Given this list of marker genes Ep400, Actr6, Ino80e, Trrap, Znhit1, Actr8, Ruvbl2, Ing3, Mcrs1, Anp32e, Ino80b, Ruvbl1, Gon4l, Dmap1, Brd8, Ino80, Yy1, Uchl5, Ino80c, Kat5, Actl6a, Nfrkb (NCBI Gene Id 235134), Cfdp1, Tfpt, Ino80d, Actr5, Srcap (Snf2-related CREBBP activator protein), here is a description of the gene set: A chromatin remodeling protein complex initially purified from S. cerevisiae and containing more than 10 subunits, including the SWR1-related complexes. INO80 (inositol requiring 80)-type complexes have diverse functions, including promoting transcriptional activation and DNA repair. studied in species Mus musculus Mouse Gene Set: GOCC_INO80_TYPE_COMPLEX